Given this list of marker genes TPP2, SCPEP1, TPP1, ACE (angiotensin I converting enzyme), CTSA, PRSS16, F11 (coagulation factor XI), HPN, CPD, DPP7, CPVL, PRCP, here is a description of the gene set: Catalysis of the hydrolysis of a peptide bond not more than three residues from the N- or C-terminus of a polypeptide chain by a catalytic mechanism that involves a catalytic triad consisting of a serine nucleophile that is activated by a proton relay involving an acidic residue (e.g. aspartate or glutamate) and a basic residue (usually histidine). species: Homo sapiens Human Gene Set: GOMF_SERINE_TYPE_EXOPEPTIDASE_ACTIVITY